Given this list of marker genes Taf1b, Taf1c, Taf1a, Tbp, Taf1d, here is a description of the gene set: species: Mus musculus Mouse Gene Set: GOCC_RNA_POLYMERASE_I_TRANSCRIPTION_REGULATOR_COMPLEX A transcription factor complex that acts at a regulatory region of a gene transcribed by RNA polymerase I.